The following is a description of a gene set: Genes down-regulated in CD4 T cells: untreated (0h) versus activated by anti-CD3 and anti-CD28 and then stimulated by IL4 (2h). Th1 and Th2 cells arise from a common precursor cell in response to triggering through the TCR and cytokine receptors for IL-12 or IL-4. This leads to activation of complex signaling pathways, which are not known in detail. Disturbances in the balance between type 1 and type 2 responses can lead to certain immune-mediated diseases. Thus, it is important to understand how Th1 and Th2 cells are generated. To clarify the mechanisms as to how IL-12 and IL-4 induce Th1 and Th2 differentiation and how TGF-beta can inhibit this process, we have used oligonucleotide arrays to examine the early polarization of Th1 and Th2 cells in the presence and absence of TGF-beta after 0, 2, 6 and 48 hours of polarization. from publication Lund R, Aittokallio T, Nevalainen O, Lahesmaa R (PMID 14607935) Human Gene Set: GSE2770_UNTREATED_VS_IL4_TREATED_ACT_CD4_TCELL_2H_DN studied in species Homo sapiens, and this is the list of marker genes: PPIH, TM4SF5, MRPL47, LAP3, FDFT1, TTC32, TUBG1, CRPPA, DKC1, MICU2, METRN, HCFC1, HADHA, EIF3L, EFTUD2, SSR1, CHML, FANCM, PSMD13, IFT80, LMO4, PINX1 (NCBI Gene Id 91819), NEIL1, ORMDL2, PSME3, SNHG32, SLC25A13, TMEM184C, POMP, UBE2T, PXMP2, FLT3, ZNG1B, HTRA2, ACYP2, MND1, ODC1, PGP, SLC45A4, SOX5, MYBPC3, GGT7, POLE, CHTF18, SPEF1, MSH2, LHFPL4, EPRS1, BAG4, FAH, NDUFAF1, NCBP3, PSMG1, RBKS, NSMCE4A, SUPV3L1, ARHGAP29, NXF2, TMTC3, CCDC110, TONSL, ATF7IP2, MAPRE2, RGCC, EMID1, MVD, TIMM23, NDUFAF7, NOP16, IQCB1 (IQ motif containing B1), TRMT5, LTK (NCBI Gene Id 4058), NDUFA10, CDCA5, PNO1, TIMELESS, ARL5A, SLC25A11, TSFM, NSMCE2, SSX2IP, ACO2, CD70, RAE1, ROPN1L, WDR90, DDIAS, TBL1X, HBG2, SNRNP27, FER, YARS1, ANGPTL4, CCT6A, HAUS4, POLR3C, COMMD5, NBN, CACNA1H (NCBI Gene Id 8912), OXLD1, HAUS5, FAM83G, HES6, PFKFB1, ATP8A1, ALDH16A1, UBE2D2, SF3A1, AKR1E2, SLX4, H2BC5, PPFIBP1, NHERF4, NPAT, POLH, AKIP1, DYNC2I2 (dynein 2 intermediate chain 2), MED8, HMGB3, MPHOSPH6, NSUN2, VSNL1, MTM1, CDC7, TAF6, ECHDC1, MRPL27, KCTD20, PTEN, FANCL, MIF, GALNT2, E2F2, ADAMTSL4, KIF22, RBBP8, ELOVL6, WDSUB1, UMPS, BFSP2, CPSF2, WDR36 (WD repeat domain 36), GNAI3, FKBP4, CCT3, CCDC34, CISD1 (NCBI Gene Id 55847), DNAAF2, PRDM16, UBA2, METAP2, CNOT9, EIF2B1, NAA50, TTC9C, SPCS1, RNLS, FAM76A, PALS2, MRPL28, FEM1B, PRADC1, ERI2, NDUFB2 (NCBI Gene Id 4708), STARD9, NUDCD1, PSMA6, ZNF706, ARL8B, NUP43, PSMD9, TESMIN, PRDX4, TIRAP, DDX28, PRPF18, XBP1, DTYMK, DMXL2, CENPL, PIDD1, ADK (NCBI Gene Id 132), MIS18A, NDUFB7, ERI1 (exoribonuclease 1), TSN, DRG1, CCDC124, SLAMF7, HMBS, ZWINT, EED, YDJC, CASP7, GOPC (NCBI Gene Id 57120), PTGR1, NME4 (NCBI Gene Id 4833), LPIN2, MRPS22, MED9